The following is a description of a gene set: Human Gene Set: GOBP_NEGATIVE_REGULATION_OF_T_CELL_MEDIATED_CYTOTOXICITY Any process that stops, prevents, or reduces the rate of T cell mediated cytotoxicity. species: Homo sapiens, and this is the list of marker genes: KLRD1, CEACAM1, IL7R, LILRB1, KLRC1, NCKAP1L, FCGR2B, PPP3CB, PTPRC, HLA-G